Given this list of marker genes ACD, POT1, RPA3, RPA1, TINF2, PCNA, POLD3, WRN, POLD4, RPA2, TERF2IP, TERF1, TERF2, POLD1, DNA2, FEN1, POLD2, here is a description of the gene set: studied in species Homo sapiens Two endonucleases, Dna2 and flap endonuclease 1 (FEN-1), are responsible for resolving the nascent flap structure. The Dna2 endonuclease/helicase in yeast is a monomer of approximately 172 kDa. Human FEN-1 is a single polypeptide of approximately 42 kDa. Replication Protein A regulates the switching of endonucleases during the removal of the displaced flap (Tsurimoto et al.1991). part of: Processive synthesis on the C-strand of the telomere Reactome Pathway: Removal of the Flap Intermediate from the C-strand